Given this list of marker genes DMTN, USP17L2, ITGB1BP1, GDI1 (NCBI Gene Id 2664), INPP5K, KCNE1, here is a description of the gene set: species: Homo sapiens Any process that decreases the frequency, rate or extent of the process of directing proteins towards a membrane, usually using signals contained within the protein. Human Gene Set: GOBP_NEGATIVE_REGULATION_OF_PROTEIN_TARGETING_TO_MEMBRANE